Given this list of marker genes GRIA3, GRIA1, GRID1, GRIA2, GRID2, GRIA4, here is a description of the gene set: Human Gene Set: GOMF_AMPA_GLUTAMATE_RECEPTOR_ACTIVITY An ionotropic glutamate receptor activity that exhibits fast gating by glutamate and acts by opening a cation channel permeable to sodium, potassium, and, in the absence of a GluR2 subunit, calcium. species: Homo sapiens